Given this list of marker genes Wdr77, Ppcdc, Leng9, Myo1c, Pex6, Lars2, Cenpx (centromere protein X), here is a description of the gene set: Genes positively differentially expressed in cell type: B cell upon treatment with cytokine: IL-17A in mouse lymph nodes in vivo. species: Mus musculus Mouse Gene Set: CUI_B_CELL_IL17A_RESPONSE_UP Cytokines mediate cell-cell communication in the immune system and represent important therapeutic targets. A myriad of studies have highlighted their central role in immune function, yet we lack a global view of the cellular responses of each immune cell type to each cytokine. To address this gap, the authors created the Immune Dictionary, a compendium of single-cell transcriptomic profiles of more than 17 immune cell types in response to each of 86 cytokines (>1,400 cytokine-cell type combinations) in mouse lymph nodes in vivo. A cytokine-centric view of the dictionary revealed that most cytokines induce highly cell-type-specific responses. For example, the inflammatory cytokine interleukin-1β induces distinct gene programmes in almost every cell type. A cell-type-centric view of the dictionary identified more than 66 cytokine-driven cellular polarization states across immune cell types, including previously uncharacterized states such as an interleukin-18-induced polyfunctional natural killer cell state. from publication Cui A, Huang T, Li S, Ma A, Pérez JL, Sander C, Keskin DB, Wu CJ, Fraenkel E, Hacohen N (PMID 38057668)